Given this list of marker genes BCKDHA, PPM1K, MCCC1, DLD, ACAT1, ECHS1, IVD, BCKDHB, AUH, MCCC2, BCKDK, DBT, HIBCH, here is a description of the gene set: studied in species Homo sapiens Reactome Pathway: Diseases of branched-chain amino acid catabolism Mutations in the genes that encode enzymes responsible for the catabolism of the branched-chain amino acids leucine, isoleucine and valine give rise to a number of inborn errors of metabolism (IEMs). Although IEMs are individually rare, collectively they are relatively common with an estimated overall prevalence of ~1:800 live births. The frequency of particular IEMs is also highly variable across different populations, a result in part of founder effects in closed populations. For instance, although the overall frequency of Maple Syrup Urine disease is 1:185,000 live births, the frequency rises to 1:380 in some Old Order Mennonite communities.<br>Accumulation of toxic intermediary metabolites causes a range of clinical phenotypes in patients with IEMs including metabolic acidosis, vomiting, seizures, psychomotor and developmental delays and death. part of: Diseases of metabolism